The following is a description of a gene set: Human Gene Set: GSE30971_WBP7_HET_VS_KO_MACROPHAGE_DN Histone methyltransferases catalyze site-specific deposition of methyl groups, enabling recruitment of transcriptional regulators. In mammals, trimethylation of lysine 4 in histone H3, a modification localized at the transcription start sites of active genes, is catalyzed by six enzymes (SET1a and SET1b, MLL1–MLL4) whose specific functions are largely unknown. By using a genomic approach, we found that in macrophages, MLL4 (also known as Wbp7) was required for the expression of Pigp, an essential component of the GPI-GlcNAc transferase, the enzyme catalyzing the first step of glycosylphosphatidylinositol (GPI) anchor synthesis. Impaired Pigp expression in Wbp7-/- macrophages abolished GPI anchor-dependent loading of proteins on the cell membrane. Consistently, loss of GPI-anchored CD14, the coreceptor for lipopolysaccharide (LPS) and other bacterial molecules, markedly attenuated LPS-triggered intracellular signals and gene expression changes. These data link a histone-modifying enzyme to a biosynthetic pathway and indicate a specialized biological role for Wbp7 in macrophage function and antimicrobial response. from publication Austenaa L, Barozzi I, Chronowska A, Termanini A, Ostuni R, Prosperini E, Stewart AF, Testa G, Natoli G (PMID 22483804) Genes down-regulated in bone marrow-derived macrophages: heterozygous versus homozygous knockout of MLL4. studied in species Homo sapiens, and this is the list of marker genes: STEAP1, GRAMD1A, RND1, ETV3, CDC42BPA, CHI3L1, ANKLE2, RAB33A, IL24, CSNK2A1, IL36G, CD48, FPR2, PLGRKT, VNN2, SOCS3, CA12, ITGB8, GNG2, MRPS10, TNFAIP6, ZFR, HLA-E, IL2RA, TNFAIP8, PIK3AP1, ADA, SMPDL3A, TNFRSF1B, TNIP3, PAPSS2 (NCBI Gene Id 9060), MIR155HG, ATL3, FKTN, LILRB3, MRPL15, EHF, IL7R, TBC1D30 (TBC1 domain family member 30), AGO2, GADD45A, SLC25A37, C1orf21, LIMK2, EEF2K (NCBI Gene Id 29904), CASP5, FCAMR, PTEN, ATF7IP, DSC2 (desmocollin 2), IL23A, PIM1, CDKN2A (cyclin dependent kinase inhibitor 2A), LMO2, AGBL4, SAMSN1, PLAT, CYB5R2, STRIP2, ENPP2, AQP9, RPIA, HYCC1, MAP3K1, BATF, CYRIA, SERPINB6, RHNO1, CRACD, CEMIP, SERPINB7 (serpin family B member 7), CCL19, LDLRAD3, CXCL1, IL7, NKX3-1, C18orf21, RAB21, TNFRSF8, RBM17, HCAR3, TFRC, SERPINB9P1 (serpin family B member 9 pseudogene 1), RALGAPA1, FLT1, SLC7A7, TRAF3IP2, P2RY6, GJB2, VNN3P, PANK3, STK26, FFAR3, SOS1, RIN2, ADGRE1, SLCO4A1, CALM1, MED13L, ACP3 (acid phosphatase 3), PIM2, INSIG2, DNAJB1, FIGNL1, VPS28, BACH1, SERPINB1, CPM, PPP1R17 (NCBI Gene Id 10842), ZC3H12A, CSF3, ARHGAP24, STAT4, SLC16A10, PLAC8, THAP1, DLGAP1-AS1, SOCS1, STAT3, IER3, SAP30BP, GOLGA2, PLD1, SASH1, FSD1L, CDC42EP5, SLAMF1, IL19, GADD45B, IL10, KLF6, FAM200C (family with sequence similarity 200 member C), OPHN1, LRIG1, GFPT2, ABHD17C, CYP3A5, LINC00343, LILRA5, P2RY2 (purinergic receptor P2Y2, NCBI Gene Id 5029), SNAPC1, PFKFB3, POU2F2, ENPP4, IER5, TLR8, DLL1, CD93, MAP3K5, NME6, TP53BP2, SYT17, TGFA, PTPN2, TRIM36, PDSS1 (decaprenyl diphosphate synthase subunit 1), HAS1, PNPLA8, CSF2, IL6, FCGR1BP, WTAP, GTDC1, SIGLEC15, RNF169, CD47, HES1, MROCKI, PTGS2, RUBCNL, RAB40C, VAV1, SLC22A1, ASAP2, AMIGO2, MIR3945HG, MRPL52, CXCL2, KTN1, POFUT1, SLC37A3, IL15RA, HDAC9, TRIP10, MAP4K4, CD274 (CD274 molecule), IBTK, PGK2, LILRB2, KANK1, ZNF319, FJX1, STON2, HLX, CAB39, PTX3, ARPC1A, HEBP2, CLGN